Given this list of marker genes CD180, PRDM5, ENC1 (ectodermal-neural cortex 1), ATP11B, FAM135A, ZNF708 (zinc finger protein 708), KIAA1217, METTL27, TBC1D4, STAB1, PRKCB, LY6D, CAMSAP1, POC1B, LRRK2, TRAF1, PCNX3, RIPOR2, PSEN2, ATL1, CREBBP, WDFY4, RCCD1, WHAMM, SLC7A14, NDNF, LY86, TNFAIP1, MFAP1, SUN2, DCAF15, PIP4K2A, TRIAP1, CDS2, PLCG1, NLK, EBF1, NFRKB, PIK3R3, DNAJB2, COQ8A, REM2, PHLPP2, ITGAX, PHRF1, SLC25A53, GXYLT1, AVPR2 (NCBI Gene Id 554), USP34, CRLF3, POLR2A, TMEM63A, SH3BP2, PREX1, TBC1D14, VPS26B, GTF2IRD2, CCL5, MAF1, VEZF1, EML5, SORBS3, MAGED1, VSIR, GGNBP2, CARD6, WFS1, C7orf57, CXXC5, CXCR5, HS3ST3B1, TSC22D4 (NCBI Gene Id 94778), ARHGDIB, ARIH2, CPM, MXD4 (MAX dimerization protein 4), ZNF608, FEZ2, FAM43A, CCDC137, MAN2C1, IGSF1, UIMC1, SAV1, GPR68, NISCH, PITPNM1, HNRNPL, ADCY7, SLC25A37, ATF7IP, NRSN2, CH25H (cholesterol 25-hydroxylase), KLRD1 (NCBI Gene Id 92677), IFNGR1, RHOBTB1, PRKAB2, LRP10, TLE3 (TLE family member 3, transcriptional corepressor), P2RX4, DDI2, MZT2B, ARFGAP2, AXIN1, PLEKHA6, CEP120, C1QTNF1, KLF7, LCMT2, GPR87, CDO1 (cysteine dioxygenase type 1), DYRK2, NCOA1, TBC1D22B, PIK3IP1, IER5, GLTP, KCTD3, PKN1, BLTP2, SLC25A40, EYA2, FOXO4, SRCAP, TGIF1, RAB14, SCD, DNTT, SLC16A7, HBP1, SELENOO, ACVR1B, C16orf54, PRKACB, LYL1, PRXL2C, EPHX1, SNX2, SDC4, QRICH1, PRKX, PSIP1, USP19, S1PR3, DTX4, FAM120B, DUSP16, PINK1, PDE3B, IKZF1, IDS, PPIP5K1 (diphosphoinositol pentakisphosphate kinase 1), MBP, TRAPPC14, SLC4A3, ERRFI1 (NCBI Gene Id 54206), PKD1, DDX6, ARF6, GRK2, FXYD5, MAP1LC3A, IRAK2, HOPX, INKA1, PIANP, PPP1R21, PARP16 (poly(ADP-ribose) polymerase family member 16), ZBTB12, ARHGAP24, SUDS3, ATG16L2 (autophagy related 16 like 2), ABCA7, WDR33, ABTB3, KMT2D, C5orf34, CLEC4F, PRPF6, SPIB, MYOF, SNTB2, ROGDI, AGTR1, RGS13, ACP5, MAPK14 (mitogen-activated protein kinase 14), JUNB, FAM167A, MAN1B1, SARAF, ZNF512, FCRLA, EVI2B, MED12, GFRA4, CD79B (NCBI Gene Id 974), GALNT11, ZMYND11, FXYD7, here is a description of the gene set: Genes down-regulated in comparison of untreated CD8 T cells versus CD8 T cells treated with leukocyte costimulatory blockade antibodies. To elucidate the gene expression “footprint” of antigenically challenged T-cells which had been treated with anti-LFA-1, CTLA4Ig, anti-CD40-ligand antibodies, we performed microarray gene expression analysis comparing the expression profile of costimulatory blockade treated and untreated responder T-cells. Human Gene Set: GSE26669_CTRL_VS_COSTIM_BLOCK_MLR_CD8_TCELL_DN studied in species Homo sapiens from publication Pearl JI, Lee AS, Leveson-Gower DB, Sun N, Ghosh Z, Lan F, Ransohoff J, Negrin RS, Davis MM, Wu JC (PMID 21362570)